The following is a description of a gene set: studied in species Mus musculus The biological process whose specific outcome is the progression of the roof of the mouth from an initial condition to its mature state. This process begins with the formation of the structure and ends with the mature structure. The roof of the mouth is the partition that separates the nasal and oral cavities. Mouse Gene Set: GOBP_ROOF_OF_MOUTH_DEVELOPMENT, and this is the list of marker genes: Anp32b, Msx1, Tmem107, Insig1, Hand2, Foxf2, Col11a2, Tiparp, Gas1 (NCBI Gene Id 14451), Gdf11, Dhrs3, Pds5a, Wfikkn1, Lef1, Intu (NCBI Gene Id 77903), Sox11, Fzd1, Ephb2, Wnt5a, Vax1, Bnc2, Tcf21 (transcription factor 21), Foxe1, Bbs7, Plekha1, Fzd2, Itgb8, Tgfb3, Itgb6, Gabrb3, Lrp6 (NCBI Gene Id 77387), Tbx3, Jag2, Prrx1, Zfp950, Wnt9b, Zfp640, Snai1, Bmpr1a, Gli3, Men1, Ephb3, Pak1ip1, Alx1, Wnt7a, Pkdcc, Tgfb2, Meox2, Ski, Loxl3, Ift172, Pdgfra, Sgpl1, Csrnp1, Msc, Snai2, Pygo2, Col2a1, Tfap2a, Fras1, Schip1, Dlx6, Inhba, Tbc1d32, Tgfbr3, Tbx2, Tgfbr2, Lrrc32, Sos1, Asph, Sumo1, Dlx5, Mmp25, Osr1, Wdpcp, Bcor, Satb2, Twist1, Fuz, Chd7, Wnt3a, Wnt8a, Tgfbr1, Wfikkn2, Arid5b, Irf6, B3glct, Osr2, Prdm16, Tshz1, Nprl3, Dlg1, Shh, Wnt11, Cdk20, Mef2c, Ift88, Ankrd11, Insig2, Cplane1 (NCBI Gene Id 73692), Alx4, Smad2, Smad4, Acvr2b, Tbx1